The following is a description of a gene set: Genes up-regulated in peripheral blood mononuclear cell 7d vs 0d in young adults (21-30) (responders) after exposure to Inactivated influenza vaccine, time point 7D Human Gene Set: THAKAR_PBMC_INACTIVATED_INFLUENZA_AGE_21_30YO_RESPONDERS_7DY_UP To elucidate gene expression pathways underlying age-associated impairment in influenza vaccine response, we screened young (age 21-30) and older (age >= 65) adults receiving influenza vaccine in two consecutive seasons and identified those with strong or absent response to vaccine, including a subset of older adults meeting criteria for frailty. PBMCs obtained prior to vaccination (Day 0) and at day 2 or 4, day 7 and day 28 post-vaccine were subjected to gene expression microarray analysis. We defined a response signature and also detected induction of a type I interferon response at day 2 and a plasma cell signature at day 7 post-vaccine in young responders. The response signature was dysregulated in older adults, with the plasma cell signature induced at day 2, and was never induced in frail subjects (who were all non-responders). We also identified a mitochondrial signature in young vaccine responders containing genes mediating mitochondrial biogenesis and oxidative phosphorylation that was consistent in two different vaccine seasons and verified by analyses of mitochondrial content and protein expression. These results represent the first genome-wide transcriptional profiling analysis of age-associated dynamics following influenza vaccination, and implicate changes in mitochondrial biogenesis and function as a critical factor in human vaccine responsiveness. from publication Thakar J, Mohanty S, West AP, Joshi SR, Ueda I, Wilson J, Meng H, Blevins TP, Tsang S, Trentalange M, Siconolfi B, Park K, Gill TM, Belshe RB, Kaech SM, Shadel GS, Kleinstein SH, Shaw AC (PMID 25596819) studied in species Homo sapiens, and this is the list of marker genes: PANK2 (NCBI Gene Id 80025), SLAIN1, RAB5C, PRMT1 (protein arginine methyltransferase 1), POLR1H, EDEM3, COIL, TMEM106C, H2BC12, FAM133B, NIN, RPF2, GOLGB1, SDHAF1, ZMPSTE24, NAPSA, TEX30, GLO1, HMGB1P1, TRIR, TP53RK, MTREX, MRPL15, SUPT3H, PPIH, ITGB3BP, ZNF845, MRPL35 (mitochondrial ribosomal protein L35), CERT1, PPIL3, MRPS23 (NCBI Gene Id 64952), IFI27L1, SLA, RBIS, TXNDC17, PFDN5, PDIA4, AP1S1, TRAM1, SEL1L3, CGGBP1, VMA21 (NCBI Gene Id 4202), TNFRSF17, GNAI3, MDP1, PEF1, MATR3 (matrin 3), MRPL14, TOMM5, MSL3, PSMC2, ITGA2B, WASHC3, MEA1, ATP5F1E, GMFB, GNL3, SLC30A9, GNB2, NDUFA6 (NCBI Gene Id 4700), CNPY2, HACD2, HAT1, CNOT6, SRP19, KIAA2013, SLC25A26, SMAP1, LARP4, EMG1, SEC61A1, ETFA, CWF19L2 (CWF19 like cell cycle control factor 2), DENND1B, IGLL1, EIF3E, TTC1, SARNP, SAC3D1, CANX, AGL, SCARNA18, SLC35C1 (solute carrier family 35 member C1), FXR1, TRAT1, MRPL51, REEP5, RRM1, CALU, RWDD1, TTC19, DNAJA2, SIRT1, RBM39, ICOS, SMARCA5, TXNDC11, CAPZA2, TCEAL8, COBLL1, ICMT, TMX1, RPRD1A, VBP1, ARMC7, MRPL24, SS18L2, SSR1, ARCN1, SMC4, OGDH, NFE2L1, SASH3, GTF2H5, HSPA8, LRR1, USP7, PYM1, DANCR, EFR3A, COX6C, YTHDF2, PTPN4, MRPL27, OCA2, ELL2, HSPE1 (heat shock protein family E (Hsp10) member 1), ACAT1, PITHD1, SCOC, SWI5, YWHAG, RBX1, MRPL11 (mitochondrial ribosomal protein L11), COX7C, CCDC32, ABI1, DNAJB11, SLC35A5, GSKIP, SEC11C, SNHG5, HINT1, VEZF1, HBQ1, HSP90B1, PPAT, RFX7, STAT5A, SDF2L1, HSD17B8, PTPN11, NDUFA4, SLC25A4, FYTTD1, RESF1, EIF3A, SLAMF7, KLRB1, PPIL1, ZNF322, NDUFA10, LRPPRC, MRPL12, ARPP19, HSPH1, HAX1, NET1, ARL6IP4, NDUFS4, NAA38, ITM2C, RPS19BP1, MANF, DNAJB14, ATP6V1D, LMAN2L, CHCHD4, FAM117B, CISD2, CERS6, THAP12, PIGF, HMGCR, STK38, KLRF1, PIGN, CPEB3, CDK4, ZNF148, MYB, TXNRD1, SCAMP1, COPS4, PTTG3P, SIVA1, CEBPZ, VCPIP1, TARS1, RPL23, ATP5MC1, BNIP3, CXCL5, MRPS18C, DMAC1, C1orf43, LSM3, VPS37A, RPS27L, ZNF428, SH3BP5L, CYTIP, BTLA, CCDC117, EIF3D, PREB, CDC42SE2, SRPRB, MYCBP2, FEN1, RPL39L, PRMT5, RALA, UQCRB, DSTN, CDC26, ELP6, PUS3, KLRD1, C2orf74, RNF181, CD52 (CD52 molecule), SLC30A7, PLEKHO2, RAB8B, EPRS1, DCP2, NOMO2, BPNT1, PARP1, BIRC2, PKIA, MBNL2 (NCBI Gene Id 55479), ACBD3, RAMAC, THEMIS, SPCS2, KRCC1, PDS5B (NCBI Gene Id 80197), RPN1, OST4, KBTBD8, CD244, MLEC, LRRN3, PHF14, GTF2E2 (general transcription factor IIE subunit 2), MOB4, RNY4, SNRPG, UBE2Z, ABCC4, GDI2, FAM13B, CEP350, CUL4B, NUDT5, ZNF480, ACADM, FIS1, UBE3A, ADORA2A, ZPR1, UBASH3B, BAK1, SERBP1, MKRN2, RLIG1, DNAJC3, SLC40A1, RPL26L1, ARF5, NDUFAF2, USP38, STIP1, NDUFA13, KDELR2, IPO11, MCUR1, SH2D1A, ST13, STYX, ROMO1, TUBA4A, CMTR2, GATD3, RPL7, UBE2T, MRPL46, IER3IP1 (NCBI Gene Id 55392), COX17, PRDX4, SSR4, GRWD1, RPAP3, PDE12 (phosphodiesterase 12), SEPTIN7, NME1, S1PR4, SCARNA16, NUDT2, CCT3, PRDX5, SLC43A3, DAD1, MRPL36, HSDL2, GPR65, MZB1, GCC1, SPNS3, DIPK1A, LDHB, MEF2C, CSE1L, TCAIM, METAP2, ACOT13, GPN1, OCIAD2, UQCC3, MRPS31, MAD2L1, HOPX, IFT27, CETN3, CCDC167, NECAP2, ACTR6, TNFRSF13B, ZNF263, MYDGF, CLN5, ABRAXAS2, TATDN2, RPL13, GP1BA, GLUD1, GRSF1, SMIM19, CHCHD7, HDHD2, GZMH, CISH, GZMM, PRPF40A, ARL5A, DCUN1D4, ZNF32, NDUFB2, IDH2, TDG, RNF20, VPS41, ITM2A, MAGEH1, CRBN, TRIP12 (NCBI Gene Id 9320), RPP40, HSP90AA1, GPX7, FH, ARHGAP15, MRPL54, SUB1, UQCC2, SMARCD2, CCT8, TOP2B (DNA topoisomerase II beta), TMEM141, TRIAP1, DPH5, ZNF613, FAR1, RAB33B, PAPOLA, LEMD3, BLOC1S5, HLTF, TMX2, LYSET, NOC3L, NAT8B, TAF7, TMEM208, VCF1, CCT6A, RAP1B, TICAM2, USP1, EMC6, WDFY1, SEC61B, GART, C6orf47, DERL1, CDKN2C, TXNDC9, PHF5A, HBB, ZNF451, HGD, NDUFB7, GGPS1, SF3B5, RPL14, MCTS1, PPP4R3A, CKS2 (CDC28 protein kinase regulatory subunit 2), CASP3, ZNF281, UQCRHL, MKKS, ODC1, GZMK, COX14, LEPR, RMI1, MED31, COX7B, HAPSTR1, UAP1, ATP5ME, TRA2B, SPCS3, RABAC1, TIMM8B, PIGK, MRPS33, ITGB1, DBI, CANT1, HDDC2, DNAJC7, DYNLT3, MRPL50, TRMT12, RNGTT, AFTPH, NARS1, USO1, FKBP2, RSL24D1, WDR33, PAICS, NCOA3, TMEM101, ASF1A, AP2B1, WDR7, KPNA3, H4C3, NUDT1, CMSS1, LMO4, LSM5, SLMAP, DYRK4, BEND2, RPL23A, PSMB5, PDS5A, UQCRC2, PLRG1, GANAB, SNX14, UPF2, ZFYVE21, GZMA, ZNF816, CDC42, AKAP8L (A-kinase anchoring protein 8 like), AK2, RPA3, ZNF146, THOC2, XRCC6, PEBP1, CMPK1, ERCC6L2, GM2A, FBXO4, CLPTM1L, FAM98A, TOMM70, NT5DC2, GIMAP7, FRG1, LY6G6F, NIPBL, PRIM1, RO60, IMPA1, GGCT, SETDB2, NRIP1, CHI3L2, KDM1A, ZNF91, PSMG4, PDZK1IP1, MRPL58, ARL6IP1 (ADP ribosylation factor like GTPase 6 interacting protein 1), NDUFA8, CEPT1, PSMC1, MBNL1, TCEAL9, DNAJC10, PUM2, PMVK, CCT2, XRN1, MRPL48, PPM1B, HACD3, GRAP2, FXR2, AGPAT1, MRPL1, LSM10, NDUFS5, STK26, PPP2R5A, TM9SF3, ZCCHC17, UBE2C, ORAI1, MIS18BP1, DDX18, ATP8B4, PCNA, RSBN1, PSIP1, MPDU1, TRAK2, PPIG, PDIA6 (protein disulfide isomerase family A member 6), MSH6 (mutS homolog 6), SUPT16H, PSMD8, CISD1, SRP68, MAN2A1, CAV1, HMGCS1, RABGAP1L, TMED2, CPNE3, UTP14A, RPA2, CES1, HDAC2, TOMM6, MDH1, SAMD9, VPS35, DNPH1 (NCBI Gene Id 10591), ZBTB33, RNF14, MIX23, AIDA, BLCAP, ATP11B, STT3A, FAM107B, DDX50, EXOC6, BOLA3, AHCY, BOLA2, COPS5, PNPLA8, CLCN3, DDX1, MIEF1 (mitochondrial elongation factor 1), CTTN, MRPS17, GORASP2, IFNAR1, UBL5, EEF1E1 (eukaryotic translation elongation factor 1 epsilon 1), CD160, RAP2A (RAP2A, member of RAS oncogene family), RAB5A, CFAP68, CPSF3 (NCBI Gene Id 51692), FOXN2, LSM1, MYNN, POLR3K, HIKESHI, MGAT1, BLOC1S1, YTHDF3, PSMD10, PDE5A, JCHAIN, ZNF586, IAH1, SYS1, COX16, CMC2, ALCAM, DYNLT2B, TAGLN2, MARCHF6, EIF2S1, CMTM5, FGFR1OP2, CRYZ, IPO8 (NCBI Gene Id 10526), ENDOD1, ZFR, ASNSD1, POMP, CD38, NDUFB3, SELENOS, GON7, HSPD1, ARMC1, SHOC2, TOR1A, SURF4, TMED3, CALR, TOR3A, DR1 (NCBI Gene Id 1810), ABHD10, MYL9, ATG101, PRUNE1, BST2, CFDP1, TMED9 (transmembrane p24 trafficking protein 9, NCBI Gene Id 96645), RDH14 (retinol dehydrogenase 14), PARVB, MGAT2, SLC38A2, GIMAP5, SEM1, UBE2J1, TXNDC5, APTX, IFI27L2, DCTPP1 (dCTP pyrophosphatase 1), COQ5